Given this list of marker genes AP3M1, DDIT4, AKIRIN2 (NCBI Gene Id 55122), STAU2, MARCHF7 (NCBI Gene Id 64844), AZIN1, TMCC1, FBN2, DNAJC5 (DnaJ heat shock protein family (Hsp40) member C5), SOX1, PRP4K, WASHC4, PCDH10, ATXN1, MAT2A, CTDSPL2, ATRX, PROSER1, IVNS1ABP, AEBP2, ETS1, NRK, SSX2IP, NDRG4, LRCH2, ZNF532, FAM91A1, RUFY3, DCBLD2, GDF10, EIF4G2, CPEB4, LRFN5, TBX1, KPNA4, BTG3, FAM76B, PAK5, NOTCH1, ANK2, MNT, CACNA2D2, TOP1, SRSF4, HDGF, XPO4, CDK19, HIPK1, FBXL16, ATP2B2, HNRNPF, MAP2, JDP2, NPTX1, SOX5, TSPAN3, DDX3X, FMR1, YWHAG, KBTBD2, HMGCR, NME7, JUN, SRSF10 (NCBI Gene Id 89048), MEIS2, FREM1, ZFAND3, APLP2, RO60, MORN4, SOCS2, SMARCA4, SEPTIN11, DMD, CDC42, CHD7, UBE2F, PIEZO1, ESRRG, RSBN1L (round spermatid basic protein 1 like), AUTS2, PPARGC1A, GRM1, TCF12, GPD1L, AP1S2, ZBTB10, RTF1, PDE3A, PPP3CB, DTX3, PSME4, LSM14A, SCHIP1, FBXL7, ZEB2, GALNT3, ARRDC3, FRMD4A, PTPRU, FOS, NFAT5, SLC25A3, HOXA9, CHFR, DHX15, NXPH1, TGIF1, DPY30, VPS37B, WDR47, MGAT4A, PMP22, FOXP1, CCNY, YWHAQ, KBTBD8, PPP2CA, PDE4A, TAOK1, UBR3, PHF6, TSPAN5, here is a description of the gene set: studied in species Homo sapiens Genes having at least one occurence of the motif ACTGTAG in their 3' untranslated region. The motif represents putative target (that is, seed match) of human mature miRNA hsa-miR-139 (v7.1 miRBase). Human Gene Set: ACTGTAG_MIR139